Given this list of marker genes RNF222, PEG10, EMP1, ABI3, NAT8L, SOX11, TM7SF3, SUPT4H1, SRP19, ZBTB34, GPR61, SRGAP3, BRD2, ZNF728, here is a description of the gene set: Human Gene Set: MIR1470 from publication Chen Y, Wang X (PMID 31504780) species: Homo sapiens Genes predicted to be targets of miRBase v22 microRNA hsa-miR-1470 in miRDB v6.0 with MirTarget v4 prediction scores > 80 (high confidence targets).